The following is a description of a gene set: part of: ABC transporter disorders studied in species Homo sapiens Reactome Pathway: Defective ABCB6 causes MCOPCB7 ATP-binding cassette sub-family B member 6 (ABCB6), uniquely located on the outer mitochondrial membrane in homodimeric form, plays a crucial role in haem synthesis by mediating porphyrin uptake into the mitochondria. Defects in ABCB6 can cause isolated colobomatous microphthalmia 7 (MCOPCB7; MIM:614497), a developmental defect of the eye resulting from abnormal or incomplete fusion of the optic fissure with associated microphthalmia (eyeballs are abnormally small). Coloboma is thought to play an important role in the early development of the CNS, including that of the eye., and this is the list of marker genes: ABCB6